The following is a description of a gene set: part of: Generic Transcription Pathway The AP-2 (TFAP2) family of transcription factors includes five proteins in mammals: TFAP2A (AP-2 alpha), TFAP2B (AP-2 beta), TFAP2C (AP-2 gamma), TFAP2D (AP-2 delta) and TFAP2E (AP-2 epsilon). The AP-2 family transcription factors are evolutionarily conserved in metazoans and are characterized by a helix-span-helix motif at the C-terminus, a central basic region, and the transactivation domain at the N-terminus. The helix-span-helix motif and the basic region enable dimerization and DNA binding.<p>AP-2 dimers bind palindromic GC-rich DNA response elements that match the consensus sequence 5'-GCCNNNGGC-3'. Transcriptional co-factors from the CITED family interact with the helix-span-helix (HSH) domain of TFAP2 (AP-2) family of transcription factors and recruit transcription co-activators EP300 (p300) and CREBBP (CBP) to TFAP2-bound DNA elements. CITED2 shows the highest affinity for TFAP2 proteins, followed by CITED4, while CITED1 interacts with TFAP2s with a very low affinity. Mouse embryos defective for CITED2 exhibit neural crest defects, cardiac malformations and adrenal agenesis, which can at least in part be attributed to a defective Tfap2 transactivation. Transcriptional activity of AP-2 dimers in inhibited by binding of KCTD1 or KCTD15 to the AP-2 transactivation domain. Transcriptional activity of TFAP2A, TFAP2B and TFAP2C is negatively regulated by SUMOylation mediated by UBE2I (UBC9).<p>During embryonic development, AP-2 transcription factors stimulate proliferation and suppress terminal differentiation in a cell-type specific manner.<p>TFAP2A and TFAP2C directly stimulate transcription of the estrogen receptor ESR1 gene. TFAP2A expression correlates with ESR1 expression in breast cancer, and TFAP2C is frequently overexpressed in estrogen-positive breast cancer and endometrial cancer (deConinck et al. 1995, Turner et al. 1998). TFAP2A, TFAP2C, as well as TFAP2B can directly stimulate the expression of ERBB2, another important breast cancer gene. Association of TFAP2A with the YY1 transcription factor significantly increases the ERBB2 transcription rate. In addition to ERBB2, the expression of another receptor tyrosine kinase, KIT, is also stimulated by TFAP2A and TFAP2B, while the expression of the VEGF receptor tyrosine kinase ligand VEGFA is repressed by TFAP2A. TFAP2A stimulates transcription of the transforming growth factor alpha (TGFA) gene. TFAP2C regulates EGFR in luminal breast cancer (De Andrade et al. 2016).<p>TFAP2C plays a critical role in maintaining the luminal phenotype in human breast cancer and in influencing the luminal cell phenotype during normal mammary development.<p>In placenta, TFAP2A and TFAP2C directly stimulate transcription of both subunits of the human chorionic gonadotropin, CGA and CGB.<p>TFAP2A and/or TFAP2C, in complex with CITED2, stimulate transcription of the PITX2 gene, involved in left-right patterning and heart development.<p>TFAP2A and TFAP2C play opposing roles in transcriptional regulation of the CDKN1A (p21) gene locus. While TFAP2A stimulates transcription of the CDKN1A cyclin-dependent kinase inhibitor, TFAP2C represses CDKN1A transcription. Transcription of the TFAP2A gene may be inhibited by CREB and E2F1.<p>For review of the AP-2 family of transcription factors, please refer to Eckert et al. 2005. Reactome Pathway: Transcriptional regulation by the AP-2 (TFAP2) family of transcription factors species: Homo sapiens, and this is the list of marker genes: APOE, TFAP2C, TGFA, YEATS4, YY1, NOP2, CITED1, MYBL2, CGA, KCTD1, TFAP2B, DEK, HSPD1, ATAD2, EGFR, TFAP2D, VEGFA, TFAP2E, SUMO1, ERBB2, KDM5B (NCBI Gene Id 10765), CREBBP, PITX2, CITED4, NPM1, KCTD15, ESR1, CDKN1A, UBE2I (ubiquitin conjugating enzyme E2 I), EP300, WWOX, CITED2, TFAP2A, CGB3, KIT (NCBI Gene Id 5086), MYC